The following is a description of a gene set: Human Gene Set: REACTOME_CHEMOKINE_RECEPTORS_BIND_CHEMOKINES Chemokine receptors bind chemokines species: Homo sapiens, and this is the list of marker genes: CCR3, CXCR5, CCL2, CXCL10, CXCL5, CCR7, CCL20, CCL5, CXCL16, ACKR2, CCL22, CXCL8, CXCL11, CCL27, CCL7, CCR9, CXCL12, XCR1, CCR2, CCL17, CCL3, CXCL2, XCL1, CXCR3, CXCR1, CXCL6, CX3CL1, CCR10, CCR1, CCL21, CXCL9, CCL25, XCL2, CCL28, CCRL2, CCR8, ACKR4, PPBP (NCBI Gene Id 90374), CXCL3, CCL19, CCL11, CXCL1, CCR5, CXCL13, CCL1, CXCR6 (C-X-C motif chemokine receptor 6), CCR4, CCL13, CCL4, CCL16, CX3CR1, CCR6, ACKR3, PF4, CXCR4, CXCR2, CCL3L3